Given this list of marker genes LHX1, PAX8, HES1, HES5, BMP4 (NCBI Gene Id 652), here is a description of the gene set: The process in which the comma-shaped body is generated and organized. The comma-shaped body is the precursor structure to the S-shaped body that contributes to the morphogenesis of the nephron. species: Homo sapiens Human Gene Set: GOBP_COMMA_SHAPED_BODY_MORPHOGENESIS